Given this list of marker genes CDYL2, TTLL12, MORC4, TP53BP1, ING4, PHF19, THAP7, MLLT3, SPIN2A, MBTD1, NCAPG2, PWWP2A, UHRF1, ING3, RAG2, DNAJC2, CBX8, BRD2, NCAPD3, ING2, UHRF2, MORC3, MECP2, PIH1D1, ATRX, MSH6, TAF3, UIMC1, PHF14, BAZ2A, TAF7, BRD1, CBX5, YEATS2, CHD1, CHD1L, PHF8, CHD5, BARD1, MDC1 (NCBI Gene Id 9656), ZMYND8, SPIN4, DPPA3, DPF2, KDM4A, BRD3 (NCBI Gene Id 9763), HDGFL2, SPIN2B, CBX2, ING1, USP15, JARID2, ING5, BRDT, TAF1, TONSL, KMT2E, H1-2, SPIN3, PHF2, FGF2, ZCWPW2, ZCWPW1, MPHOSPH8, PHF1, BRCA1, STK38, L3MBTL2, CDY1B, CDY1, BRD4, WDR5, CHD8, TDRD3, FMR1, SGF29, BRD7, CXXC1, SPIN1, PHF13, PYGO1, PWP1, L3MBTL1, ZMYND11, CCDC38, SUZ12, RNF169 (ring finger protein 169), LRWD1, RRP8, YEATS4, MTF2, MSL3, here is a description of the gene set: A chromatin adaptor activity that brings together a protein and a specific form of histone, either modified by a post-translational modification, or the unmodified form. Histone readers have roles in many processes, including in centromere function or in modulating the accessibility of cis-regulatory regions to the transcription machinery. Human Gene Set: GOMF_HISTONE_READER_ACTIVITY species: Homo sapiens